Given this list of marker genes UBE2V2, HP1BP3, LNPK, NSMCE1, RNF145, MFSD14A, UBE2V1, OMG, OSBPL1A, CNOT9, UBE2J1, LRRTM1, MED13, RAB5C, MCU, EYA4 (NCBI Gene Id 56002), HEMGN, MTF2, PTBP2, SLC30A4, GOLGA6L4, SEC14L1, KIF13B, RECQL, FNIP1, STC1, COG5, PDCD4, ETS1, CSNK2A2, CREBZF, CNKSR2, REEP1, SLC6A13, GOLGA6L9, FOXN2, KDM7A, NLK, EBF1, VPS13C, TSPAN12, SOX6, RIMS1, YBX1, SNX2, here is a description of the gene set: species: Homo sapiens Human Gene Set: MIR208B_3P Genes predicted to be targets of miRBase v22 microRNA hsa-miR-208b-3p in miRDB v6.0 with MirTarget v4 prediction scores > 80 (high confidence targets). from publication Chen Y, Wang X (PMID 31504780)